Given this list of marker genes MAPK1, SOS1, GRB2, ARAF, MAP2K1, EGFR, RAF1, KRAS, CCND1, MAP2K2, MAPK3, NRAS, SOS2, HRAS, BRAF (B-Raf proto-oncogene, serine/threonine kinase), here is a description of the gene set: species: Homo sapiens Mutation-activated EGFR to RAS-ERK signaling pathway. Pathway ID: N00014. Pathway type: Variant. Pathway class: nt06266 Non-small cell lung cancer. Human Gene Set: KEGG_MEDICUS_VARIANT_MUTATION_ACTIVATED_EGFR_TO_RAS_ERK_SIGNALING_PATHWAY Pathway Definition from KEGG: EGFR* -> GRB2 -> SOS -> RAS -> RAF -> MEK -> ERK -> CCND1